The following is a description of a gene set: species: Mus musculus Mouse Gene Set: GOMF_NADPLUS_PROTEIN_GLUTAMATE_ADP_RIBOSYLTRANSFERASE_ACTIVITY Catalysis of the reaction: L-glutamyl- + NAD+ = 5-O-(ADP-D-ribosyl)-L-glutamyl- + nicotinamide., and this is the list of marker genes: Parp16, Parp3, Parp1, Parp2, Parp10, Parp14, Parp4, Tnks, Tnks2, Parp11, Tiparp